The following is a description of a gene set: from publication Chen Y, Wang X (PMID 31504780) Genes predicted to be targets of miRBase v22 microRNA hsa-miR-7847-3p in miRDB v6.0 with MirTarget v4 prediction scores > 80 (high confidence targets). species: Homo sapiens Human Gene Set: MIR7847_3P, and this is the list of marker genes: GFPT1, ELK1, PRKAR2A, KLF8, SLC35C1, NECAB2, MAPKBP1, ZNF529, NLK, CLIC1 (chloride intracellular channel 1), PIGK, PXK, LAMC1, PDGFB, LYPD1, RPRD1A, SYK (NCBI Gene Id 6850), CREB3L2, KIF1A, TBKBP1, AXIN2, KPNA3, STAG2, EXPH5, MYO16, ZKSCAN3, GAREM2, LDB1, ENPP6, RANBP10, NRP2, DZIP1L, PDE6D, SLC39A8, ZNF221, CLSTN2, DENND1A, PRICKLE2, ATP1B4, AP1S1, SH3BGRL2, GLRX, PDAP1, PDK2, FMOD, GRID2, LYRM1, MYEF2, SEZ6, ADAMTS9, PSKH1 (protein serine kinase H1), MLLT10, ATG7, GAS7, RAB1A, SNN, KCMF1, CALN1, ASB12, CYP3A4, BMP3, ZNF784, PHF21A, CHMP1B, SYP, SLC22A23, NKAIN1, PEA15, LHPP, SLC25A21, RHOBTB1, GSPT1